Given this list of marker genes BCAR1, FGG, ITGA2B, SRC, FN1, CRK, RAP1B, VWF, FGA, APBB1IP, TLN1, RAP1A, ITGB3, FGB, PTK2, here is a description of the gene set: studied in species Homo sapiens part of: Integrin signaling Reactome Pathway: p130Cas linkage to MAPK signaling for integrins Integrin signaling is linked to the MAP kinase pathway by recruiting p130cas and Crk to the FAK/Src activation complex.